Given this list of marker genes SEMA4D, RAC1, CDK5, SEMA3E, PAK2, PIP5K1C, CRMP1, SEMA4A, CDK5R1, PLXNA3, SEMA6A, RHOB, PLXND1, LIMK2 (NCBI Gene Id 3985), RND1 (NCBI Gene Id 27289), PLXNA1, DPYSL4, DPYSL2, SEMA7A, PTPRC, MYL9, RHOA, TREM2, RHOC, MYL12B, ITGB1, FYN, MYH11, MYH9, PAK1, CD72, PLXNA4, LIMK1, TYROBP (NCBI Gene Id 7305), SEMA5A, PLXNA2, MET (MET proto-oncogene, receptor tyrosine kinase), HSP90AB1 (NCBI Gene Id 3326), MYH10, PAK3, ROCK1, FES, DPYSL3, CFL1, DPYSL5, ARHGEF11, HSP90AA1, NRP1, GSK3B, PLXNC1, MYH14, SEMA3A, RRAS, PLXNB1, FARP2, ARHGEF12, ERBB2, ARHGAP35, TLN1, PLXNB3, SEMA6D, ITGA1, ROCK2, MYL6, here is a description of the gene set: Semaphorin interactions species: Homo sapiens Human Gene Set: REACTOME_SEMAPHORIN_INTERACTIONS